The following is a description of a gene set: Human Gene Set: GSE21360_PRIMARY_VS_SECONDARY_MEMORY_CD8_TCELL_UP species: Homo sapiens from publication Wirth TC, Xue HH, Rai D, Sabel JT, Bair T, Harty JT, Badovinac VP (PMID 20619696) The transcriptome of naive OT-I T cells was compared to memory CD8 T cells after 1, 2, 3, or 4 infection with ovalbumin expressing Listeria monocytogenes (LM-OVA). Genes up-regulated in 1'Memory CD8T versus 2'Memory CD8T., and this is the list of marker genes: FABP7, PRKAR1A, CCPG1, NCBP1, DNASE1 (deoxyribonuclease 1), TMEM262, DSN1, KRT8P12, BORA, SLC1A3, MICU2, EPB41L1, ZNF287, CDC27, PABPC3, ETFDH, ACSL4, KRTAP1-1, REST, CACNA1H, FAM131B, H2AC13, NRCAM, AGA, OR2F1, ZBTB7C, C10orf88, SLC47A1, CTRC, GLS, PTGS2, ERG, SCTR, LGSN, OPLAH, FGGY, PPP4R3B, KRT14, DLST, RRS1, DNAJC17, LCOR, GPN3, CACNA1I, ZBTB7B, CCDC82, RPGRIP1, GAB2, DEPP1, OLFML1, PLEKHF2, SLC5A12, KRIT1, SERBP1, AMPD1, ARFIP1, HNF1A, IFNA8 (interferon alpha 8), MATN4 (matrilin 4), PAX6, RPS3A, AKAP4, XPOT, NRIP2, IGLV3-19, SPINK1, GRIN2D, CFAP74, ACKR3, ARHGEF26, BCAP29, SLC15A2, ARMCX5, THBS3 (NCBI Gene Id 7059), NUBPL, TRIM45, SMTN, ATP2B2, PRG3, STRN3, LRP2, LRRC19, APCS, H2BC9, IL1RAP, NKX3-2, RPGRIP1L, ELAPOR1, TMEM33, NTN3 (netrin 3), TSKS, TMEM45A, RECQL, IL32, DHX29, DNAJC7, ZBTB5, MAK16, OR52A1, GPR21, PLA2G15, UBE2NL, CRCP (CGRP receptor component), GNG4, HOXB9, NUP160, ZNF7, LLPH, RBM8A, MYBPC3, HNRNPUL2, MTR, MMUT, VPS33A, MYH15, GADD45G, EAF2, HSP90AB1, HOMER2, ZKSCAN5, IFT27, IHH, MAGEB3, CETN2, FOXN1, DMBT1, NEU2, PPP5C, ZNF16, HPSE2, UPB1, IREB2, NAA50, GLRX3, KCNIP2, FGF3 (NCBI Gene Id 2248), PEX1, TBC1D12, LAIR1, NCBP2, PIWIL1, GPR6, EMC2, ZBTB6, MAPK4, GABRG3, RXRG, DNAJC10, KRTAP2-4, CRYAB, ALDH7A1, LIPG, FAM234B, TSNAX, TBC1D9, GPR87, ZBED4, JPH3 (junctophilin 3), LIG3, HDAC2, LYPLA1, CD68, TPST1, RTN4, SNX24 (NCBI Gene Id 28966), COMMD8, SPARC, APBB1IP, MRS2, GHSR, HACD2, ULBP1, VLDLR, ADSS2, ANP32E, HCCS, COBL, TTC33, CELA3A, FKBP1A, TBX3, MICU1, PLEKHG6, H1-4, SMAD5-AS1 (NCBI Gene Id 9597), TM4SF1, STAG1, EPB41, CD34, RAB33B, ZNF80, H2BC7, ZNF460, SPATA7, PCNP, BMP8B, AOC3, SPICE1, ZNF385D